Given this list of marker genes PER2, RABGGTA, ELOA, GRK5, TOR1AIP2, NANOG, SLC25A28, PNPT1, EIF2AK2, CD5 (CD5 molecule), IRGM, ZNF841 (zinc finger protein 841), EIF3C, IRF4, SH3BGRL, COX17, HHEX, WBP4, TUBA4A, ATAD1, OGFR, STXBP3, POLR3A, TRIM21, MTHFR, VPS53, RMDN3 (NCBI Gene Id 55177), PABPC1, CCND2, ZRANB1, PML, LYL1, NMI, TMEM50B, KAT2B, APOA2, COX18, LGALS3BP, BRAF, CEBPB, CTSS, CREG1, B3GNT2, TBP, TCOF1, COCH, STAT1, XPO6, SAT1, TRIM25, LCLAT1, SYNGR2, IL15RA, IRF9, NFKB1 (NCBI Gene Id 4790), LRP6, ATF3, AKIRIN2, ASL, EEA1, CBX4, EDEM3, AZIN1 (antizyme inhibitor 1), GNL2, USP18, MX2, SKIL, B2M, CLN3, GEMIN5, SLCO3A1, HLA-C, NOC4L, IPO4, IFIH1, RSAD2, IFIT1B, SOCS1, RGS10, PABPN1, TIMELESS, PDLIM1, UBA7, FAM3C, ISYNA1, EPHB2, SYNJ2BP, PSME2, NAMPT, TRAFD1 (TRAF-type zinc finger domain containing 1), HLA-E, SFXN2, SMAD3 (SMAD family member 3), IFI27, NDST1, PRKCA (protein kinase C alpha), TAP1, ISG15, USP15, IL6R, FABP9, PARP6, ARL14EP, SHISA5, GPAA1, TRAF6, CMTR1, PPP2R3C, PCDHA12, MX1 (NCBI Gene Id 4599), NR5A2, ZNFX1, CMPK2, DNAJA3, MOV10, RABEP1, EXOSC10 (NCBI Gene Id 8619), SFT2D1, PPA1, WDSUB1, HMCES, NFATC1, ANTXR2, NAT1, NRBP1, SCAF8, ADAR, NMT2, NCOA3, CERS2, CMTM6, VIPR2, FAM117A, TYMP, SEC23A, SLC7A7, ISG20, DAXX, MAT2A, IRF7, ATP1A1, DDX24, LGALS9B, PHC2, POLDIP3, IFI27L2, NCAM2, PELO, IFI35, CCNDBP1, CLCNKB, GNG12, GAS8, EDN2, ICAM2, OTUD7B, TAPBP, SERPINC1, GTPBP2, TNF, CCRL2, AGRP, ETNK1, SMYD5, STARD3, PSME1, PCK2, SIN3A, CAB39L, SRPRA, SPRED2, TMEFF2, GALR1, MTX2, SEC62, PUM3, PIGS, WNT10A, HLA-B, USP19 (NCBI Gene Id 10869), DNAJC2, CISH, PIGU, DUSP6, ST6GALNAC5, RRP1B, CCR6, ATP13A1, TAP2, KMT5A, SLFN12L, LAPTM4B, MARCHF5, USP25, FASTKD5, CHCHD10, HMGN5, SAMHD1, SERPINH1, TNPO2, here is a description of the gene set: from publication Agarwal P, Raghavan A, Nandiwada SL, Curtsinger JM, Bohjanen PR, Mueller DL, Mescher MF (PMID 19592655) Differentiation of naive CD8 T cells into cytotoxic effector cells requires three distinct signals- antigen (signal 1), costimulation -B7-1 (signal 2) and cytokine, either interleukin-12 or interferon-a/b (signal 3). Interaction of naive CD8 T cells with antigen and B7-1 programs cell division and proliferation whereas the presence of cytokines- IL-12 or IFNa/b promote survival, differentiation and memory establishment. In the absence of signal 3, the cells interacting with antigen/B7-1 undergo tolerance induction. The objective of this study was to elucidate the mechanisms how the provision of signal 3 promotes differentiation and averts tolerance induction in CD8 T cells. Trichostatin A is a pharmacological agent that inhibits histone deacetylase activity, hence regulating chromatin structure and gene expression and differentiation in many cell types. Gene signature profiles of IL-12, IFNa/b and trichostatin A stimulated cells were compared to elucidate the molecular mechanisms of gene regulation. Oligonucleotide microarray analysis is carried out to determine the extent and molecular nature of the CD8 T cell differentiation program induced by IL-12 or IFNa/b in concert with antigen and B7-1 signal. studied in species Homo sapiens Genes down-regulated in comparison of unstimulated CD8 T cells at 48 h versus CD8 T cells at 48 h after treatment with trichostatin A (TSA). Human Gene Set: GSE15930_STIM_VS_STIM_AND_TRICHOSTATINA_48H_CD8_T_CELL_DN